The following is a description of a gene set: species: Homo sapiens The process of directing proteins towards the vacuole using signals contained within the protein, occurring as part of autophagy, the process in which cells digest parts of their own cytoplasm. Human Gene Set: GOBP_PROTEIN_TARGETING_TO_VACUOLE_INVOLVED_IN_AUTOPHAGY, and this is the list of marker genes: SMURF1, SQSTM1, CLU, HSPA8, LAMP2, IRGM